The following is a description of a gene set: INTRODUCTION: Molecular characterization of the normal epithelial cell types that reside in the mammary gland is an important step toward understanding pathways that regulate self-renewal, lineage commitment, and differentiation along the hierarchy. Here we determined the gene expression signatures of four distinct subpopulations isolated from the mouse mammary gland. The epithelial cell signatures were used to interrogate mouse models of mammary tumorigenesis and to compare with their normal human counterpart subsets to identify conserved genes and networks.METHODS: RNA was prepared from freshly sorted mouse mammary cell subpopulations (mammary stem cell (MaSC)-enriched, committed luminal progenitor, mature luminal and stromal cell) and used for gene expression profiling analysis on the Illumina platform. Gene signatures were derived and compared with those previously reported for the analogous normal human mammary cell subpopulations. The mouse and human epithelial subset signatures were then subjected to Ingenuity Pathway Analysis (IPA) to identify conserved pathways.RESULTS: The four mouse mammary cell subpopulations exhibited distinct gene signatures. Comparison of these signatures with the molecular profiles of different mouse models of mammary tumorigenesis revealed that tumors arising in MMTV-Wnt-1 and p53-/- mice were enriched for MaSC-subset genes, whereas the gene profiles of MMTV-Neu and MMTV-PyMT tumors were most concordant with the luminal progenitor cell signature. Comparison of the mouse mammary epithelial cell signatures with their human counterparts revealed substantial conservation of genes, whereas IPA highlighted a number of conserved pathways in the three epithelial subsets.CONCLUSIONS: The conservation of genes and pathways across species further validates the use of the mouse as a model to study mammary gland development and highlights pathways that are likely to govern cell-fate decisions and differentiation. It is noteworthy that many of the conserved genes in the MaSC population have been considered as epithelial-mesenchymal transition (EMT) signature genes. Therefore, the expression of these genes in tumor cells may reflect basal epithelial cell characteristics and not necessarily cells that have undergone an EMT. Comparative analyses of normal mouse epithelial subsets with murine tumor models have implicated distinct cell types in contributing to tumorigenesis in the different models. Genes consistently down-regulated in mature mammary luminal cells both in mouse and human species. from publication Lim E, Wu D, Pal B, Bouras T, Asselin-Labat ML, Vaillant F, Yagita H, Lindeman GJ, Smyth GK, Visvader JE (PMID 20346151) studied in species Mus musculus Mouse Gene Set: LIM_MAMMARY_LUMINAL_MATURE_DN, and this is the list of marker genes: Cryab, Ltbp4, Bace2, Dab2, Nfib (NCBI Gene Id 77183), Vim, Jag2, Cygb, Fzd1, Meis2, Aebp1, Igfbp3, Pcf11, Cyria, Fabp5, Sparcl1, Lmo4, Reck, Tpst1, Tmem47, Gas6, Stac2, Kctd12, Rasa3, Epb41l2, Tgfbr3, Tfap2c, Serpinh1, Tspan2, Gpx7, Lrig3, C1qbp, Slc1a3, Tshz2, B4galt6, Mertk, Camk2d, Fam13a, Dpysl2, Tiam2, Axin2, Itpkb (inositol 1,4,5-trisphosphate 3-kinase B), Snai2, Cald1, Bcl11a (BCL11 transcription factor A), Nrep, Ccl2, Foxn3, Sox10, Rap2b, Pdzrn3, Ntrk2, Tinagl1, Hey2, Fbxo32, Sfrp1, Nes, Gypc, Nrtn, P3h2, Col16a1, Moxd1, Fas, Prickle1, Fstl1, Tubb6, Col6a2, Abtb3, Fam171a1, Slc6a15, Irx1, Egfr, Pakap, Htra1, Fam181b, Irs2, Foxo1, Col6a1, Lama1, Col4a1, Lpl, Mob3b, Frmd4a, Col4a2, Apoe (NCBI Gene Id 11816), Zfp521, Sorbs1, Rasl12, Ets1, Casp1, Tle4, 1700019D03Rik, Wtip, Aqp9, Map4k4